The following is a description of a gene set: Fatty acid and lipoprotein transport in hepatocytes species: Homo sapiens Human Gene Set: WP_FATTY_ACID_AND_LIPOPROTEIN_TRANSPORT_IN_HEPATOCYTES, and this is the list of marker genes: ACLY, ACSL3, AP2S1, PEX2, CLCN5, PRSS12, CTTN, LOXL3, EHHADH, STON2, ECHDC2, CFTR, AMPH, STON1, FCHO2, INPPL1, LY75, BECN1, ACAD10, HOOK2, APP, SNX2, APOC4, CLEC9A, DBI, LRP8, TMPRSS4, HMGCS1, CSNK1G3, G6PD, LRP3, ABCD2, PLPP6, PON1, SAA1, RHOU (ras homolog family member U), DNM1, LPL, AP3M2, CYTH2, DAB2, LRP2, ACKR4, LDLR, SORT1, ECI1, ACAA2, RAB22A (RAB22A, member RAS oncogene family), SOAT2, RHOV, REPS1, REPS2, FNBP1, MIB1, PPARD, CLN3, HMGCS2, SNX9, CETP, APOC1, STEAP2, ENPP1, ARRB2, CDC42, EHD1, SNX18, INSIG1, CSNK1G2, LRP1, ECHS1, EEA1, LCAT, TMPRSS3, BIN3, ABCD3, AP2A2, HRAS, MARCHF3, SRL, ABCA1, NPC2, SHH, APOC3, PIK3CB, ACSL5, LEP, APOC2, DECR1, SLC27A3, CD6, SYP, LMBR1L, RABEP2, APOO, DHCR7, ABL1, LRP5, ECI2, ACOX3, ACSL1, SERINC1, FDPS (farnesyl diphosphate synthase), HADHA, ITSN1, LSS, EHD2, MARCO, SOAT1, TMPRSS15, PIK3C2A, PRG4, CD163L1, PIK3C3, MICALL1, LRRK2, ZFYVE9, CLEC4F, SAA4, APOL1, LPA, SLC27A2, LIPA, MRC2, CD5L, APOA4, RUFY1, EBP, LSR, APLP1 (NCBI Gene Id 333), STAB2, LDLRAP1, SSC4D, SESN2, RHOJ, NECAP1, ARR3, TMPRSS2, LRP6 (NCBI Gene Id 4040), AP3M1, APOBR, AP2B1, UNC119, STON1-GTF2A1L, PACSIN2, MRC1, APOF, SNX10, SH3BP4, RIN1, CPT1B, AP2A1, NPC1, LIPC, ABCD4, RAB5B (NCBI Gene Id 5869), MYLIP, CAV3, MIA3, CLTA, ENTHD1, RALBP1, PRKAA1, RHOQ, HEATR5A, APOA1, TM7SF2, LRP1B, PIP5K1C, GHR, OLR1, ASGR2, RIN3, CLINT1, FDFT1, TMPRSS13, FCHSD2, VLDLR, TNK2, HEATR5B, SH3GL3, PACSIN1, AUH, DNM1L, RAB7A, EHBP1, FABP4, CALY, DNER, HSD17B7, CLIP3, CD5, SURF4, LRP12, STARD3, LGALS3BP, ITSN2, DBNL, CD163, CUBN, CD320, SORL1, TOM1 (NCBI Gene Id 10043), CPT1A, PIK3CG, ENPP2, EPN2, OCIAD1, SCP2, ACAT1, INSIG2, NPC1L1, OCIAD2 (NCBI Gene Id 132299), PMVK, CSNK1G1, TRIP10 (thyroid hormone receptor interactor 10), ARHGAP27, EPS15, LOXL4, TSC2, SCARA5 (NCBI Gene Id 286133), ACOXL, MSR1, HDLBP, HADH (hydroxyacyl-CoA dehydrogenase), SH3GL2, PGBD1, ANK2, SSC5D, EPN3, APOA2, SH3GL1, LRP10, PCYOX1, RUBCN, RAB17, EQTN, ACAT2, RABGAP1L, TMPRSS5, MCAT, TFRC, WASF2 (NCBI Gene Id 10163), ACAD11 (NCBI Gene Id 84129), NSDHL, ATP9B, CES1, SLC5A8, SYNJ1, BTBD8, VTN, PEX7, C9orf72, TEX261, DPYSL2, PSTPIP1, FABP1, MVD, SCARB2, HIP1, SYNRG, AAK1, APOB, EHD4, RAB34, BCL2L1, ATP6V1H, MTMR6, DNM3, MARCHF2, PEX5, HIP1R, CROT, SCARA3, MIA2, NECAP2, AP2M1, SLC27A4, ECHDC1, CYP51A1, ACADM, CLEC10A, DENND1C, ILDR1, DNM2, USP33, PCSK9, MSMO1, OSBPL5, HSD17B4, ATP9A, CFI, RABGEF1, EPS15L1 (epidermal growth factor receptor pathway substrate 15 like 1), MTLN, APOM, CPT2, MYO6, CPT1C, ACSL6, LBR, PACSIN3, ARC, ACAA1 (acetyl-CoA acyltransferase 1), IDI2, FNBP1L, USP20, LMBRD1, SNX33, PLA2G7, OPHN1, SLC25A17, CYB5R3, STAR, FABP2, RABEP1, ESYT2, SCARF2, NOSTRIN, BDH2, DMBT1, APOA5, HSD17B10 (hydroxysteroid 17-beta dehydrogenase 10), ABCD1, EHD3, MVK, SIGLEC1, SCAMP1, ENDOU, ASGR1, RIN2, RINL, HMGCR, FCHO1, RAB5C, BIN1, NCKIPSD, APOH, FKBP15, RAB1A, HHIPL1, SAA2, ACADS, APOE, ANKFY1, MTMR9, ADIPOQ, EPN1 (NCBI Gene Id 29924), SCARB1, VDAC1, ACKR2, PRKAA2, IDI1, GAPVD1, LOXL2 (NCBI Gene Id 4017), SELENOS, DGKD, DHCR24, PLTP, SNX5, SLC27A1, CD209, SH3KBP1, PLA2R1, ACOX2, AGER, ARV1, CSNK1E, FABP3, ACOX1, NME1, LRP4 (NCBI Gene Id 4038), SAA2-SAA4, MYO1E, CLEC4M (NCBI Gene Id 10332), HADHB, RAB5A, DENND1A, ECH1, DENND1B, SGIP1, PICALM